Given this list of marker genes Ercc1, Cdkn1a, Nucks1, Trp53, Sfrp2 (NCBI Gene Id 99743), Brcc3, Ercc6, Xrcc2, Gata3, Lrp2, Pmaip1, Brca2, Trp53bp1, Xrcc4, Atm, Nipbl, Xrcc5, Blm, Ccnd2, Casp3, Xrcc6, Ercc8, Rad51, Msh2, Lig4, Prap1, Thbd, Lcn10, Sfrp1, Kars1, Xrra1, here is a description of the gene set: studied in species Mus musculus Any process that results in a change in state or activity of a cell or an organism (in terms of movement, secretion, enzyme production, gene expression, etc.) as a result of X-ray radiation. An X-ray is a form of electromagnetic radiation with a wavelength in the range of 10 nanometers to 100 picometers (corresponding to frequencies in the range 30 PHz to 3 EHz). Mouse Gene Set: GOBP_RESPONSE_TO_X_RAY